Given this list of marker genes Hint1, Nod1, Apol9b, Niban1, Myc, Itgae, Socs2, Ankrd17, Smpdl3a, Slc30a7, Nop53, Psmd4 (NCBI Gene Id 19185), Tmem65, Glud1, Nrip1, Rnh1, Sh3bp5, Ctla4, Zfp622, Fam107b, Resf1, Cd44, Ikzf2, Selenok, Sema4a, Syt11, Igf1r, Cyfip1, Lrig1 (leucine-rich repeats and immunoglobulin-like domains 1), Endod1, Sc5d, Il2rb, Timm10, Snx14, Bmpr2, Plekhb2, Dennd5a, Rora, Maf1, Ttc39b, Capg, Rragd (Ras-related GTP binding D), Itga6, Nt5e, Psmd8, Ahcy, Etfbkmt, Stat4, Inpp5f, Larp1b, Sh3bgrl, Nrp1, Itgb8, Foxp3, Adss1 (adenylosuccinate synthase 1), Nucb2, Gucy1a1, Hipk1, Xbp1, Ston1, Odc1 (ornithine decarboxylase, structural 1), Plaat3, Tiam1, Il2ra, Atp10d, Irf4, Calhm6, Rpn2, Tnfrsf9, Cd38, Syngr2, Plscr1, Itgb1, Snx18, Penk, Btg2, Gvin1, Cd48, Mthfs, Ppm1l, Gpx4, Psmb3, Otulin, 1110032F04Rik, Kars1, Stx11, Trbv14, Ahnak, Itgav, Il1r2, Arf1, Smu1, Wls, Mettl17, P2rx7, Gprin3, Drg1, Ywhaq, here is a description of the gene set: Mouse Gene Set: GAVIN_FOXP3_TARGETS_CLUSTER_T4 studied in species Mus musculus Regulatory CD4+ T cells (Tr cells), the development of which is critically dependent on X-linked transcription factor Foxp3 (forkhead box P3), prevent self-destructive immune responses. Despite its important role, molecular and functional features conferred by Foxp3 to Tr precursor cells remain unknown. It has been suggested that Foxp3 expression is required for both survival of Tr precursors as well as their inability to produce interleukin (IL)-2 and independently proliferate after T-cell-receptor engagement, raising the possibility that such 'anergy' and Tr suppressive capacity are intimately linked. Here we show, by dissociating Foxp3-dependent features from those induced by the signals preceding and promoting its expression in mice, that the latter signals include several functional and transcriptional hallmarks of Tr cells. Although its function is required for Tr cell suppressor activity, Foxp3 to a large extent amplifies and fixes pre-established molecular features of Tr cells, including anergy and dependence on paracrine IL-2. Furthermore, Foxp3 solidifies Tr cell lineage stability through modification of cell surface and signalling molecules, resulting in adaptation to the signals required to induce and maintain Tr cells. This adaptation includes Foxp3-dependent repression of cyclic nucleotide phosphodiesterase 3B, affecting genes responsible for Tr cell homeostasis. from publication Gavin MA, Rasmussen JP, Fontenot JD, Vasta V, Manganiello VC, Beavo JA, Rudensky AY (PMID 17220874) Cluster T4 of genes with similar expression profiles in thymic T lymphocytes after FOXP3 loss of function (LOF).